Given this list of marker genes TRPV4, PDE4DIP, KATNB1, NUMA1, MAP1B, SPAST, MECP2, NAV3, MAPRE1, AURKB, CLASP1, STMN2, ARL2, DRG1, OCLN, ANKRD53 (ankyrin repeat domain 53), RAC1, CAV3, DCTN1, CDKN1B, HSPA1B, PAK1, SLAIN1, GIT1, CLIP1, MET, CKAP5, HSPA1A, PSRC1, MAPT, CDK5R1, TOGARAM1, RPS3, CDK5RAP2, SKA1, SLAIN2, FES, AKAP9, here is a description of the gene set: Human Gene Set: GOBP_POSITIVE_REGULATION_OF_MICROTUBULE_POLYMERIZATION_OR_DEPOLYMERIZATION Any process that activates or increases the frequency, rate or extent of microtubule polymerization or depolymerization. studied in species Homo sapiens